Given this list of marker genes Kcnip2, Kcnb1, Dlg2, Cntnap2, Akap5, Cntn2, here is a description of the gene set: Mouse Gene Set: GOBP_CLUSTERING_OF_VOLTAGE_GATED_POTASSIUM_CHANNELS The process in which voltage-gated potassium channels become localized together in high densities. In animals, voltage-gated potassium (Kv) channels are clustered beneath the myelin sheath in regions immediately adjacent to paranodes, called juxtaparanodes, and along the inner mesaxon within the internode. studied in species Mus musculus